Given this list of marker genes TMEM59L, NPTXR, PGBD5, CLIP3, AMPH, YWHAH, SNAP91, KIF5C, EPB41L1, SLC17A7, NMNAT2, RALYL, CAMTA1, TAGLN3, CORO2B, SLC22A17 (solute carrier family 22 member 17), TYRO3, RPH3A, BSN, NUAK1, RCAN2, MAPT, GAP43 (growth associated protein 43), NRN1, FXYD7, SLC1A3, DIRAS2, MAP1A, ARNT2, SNAP25, SH3GL2, ATP6V1G2, SYT1, RAB6B, ARHGEF9, SNCB, CAMK2A, CA11, STXBP1, NAP1L2, PSD3, TSPAN7, CAMK2B, RGS7, GDI1, SYT11, VAMP2, PHYHIP, KCNQ2, OLFM1, GNG3, DNM1, NAP1L3, SLC12A5, ATP2B2, RAB3A, FAIM2, SV2A, VSNL1, CTNND2, PNMA2, CHN1, SYN1, SV2B, ZNF365, RBFOX1, CAMK2N1, RUNDC3A, PREPL, GABBR2, SULT4A1, EHD3, GABRA1, NDRG4, here is a description of the gene set: Human Gene Set: GNF2_DNM1 Neighborhood of DNM1 dynamin 1 in the GNF2 expression compendium Neighborhood of DNM1 studied in species Homo sapiens